Given this list of marker genes ATF3, KMT2A, ZMYM3, GPR85, PAXBP1, PITPNM3, NR2F1-AS1, ANAPC7, HAR1A, EPCIP-AS1, GOLM2, MED15P9, CRYBB2, BRWD3, LINC00114, KRTAP9-6, here is a description of the gene set: Human Gene Set: ERCC8_TARGET_GENES Genes containing one or more binding sites for (ERCC8) in their promoter regions (TSS -1000,+100 bp) as identified by GTRD version 20.06 ChIP-seq harmonization. from publication Yevshin I, Sharipov R, Kolmykov S, Kondrakhin Y, Kolpakov F (PMID 30445619) species: Homo sapiens